The following is a description of a gene set: Genes predicted to be targets of miRBase v22 microRNA mmu_miR_6973a_3p in miRDB v6.0 with MirTarget v4 prediction scores > 80 (high confidence targets). Mouse Gene Set: MIR_6973A_3P species: Mus musculus from publication Chen Y, Wang X (PMID 31504780), and this is the list of marker genes: Lonrf1, Efr3a, Asgr1, Plek, Msx3 (NCBI Gene Id 212466), Mgl2, Ankrd28, Dgke, Slc38a6, Tusc1, Zfp652, Lsm5, Pex13, Kdm2a, Lipo2, Dcc, Mdc1, Dstn, Ccdc73, Scn2a, Kpna4, Cask, Phf6, Slc35f5, Hes7, Wasf1, Eif4a2, Cd28, Usp38, Tmprss11d, Clpb, Yipf5, Wdr76, Hc, Uty, Bola3, Pmaip1, Arhgap39, Ereg, Bmpr1a, Psd3, Dync1li2, Apob, Slc16a2, Dennd5a, Plekha8, Clta, Pcmtd2, Edil3 (EGF-like repeats and discoidin I-like domains 3), Tmc7 (transmembrane channel-like gene family 7), Cdk13, Chrnb1, Gpm6a, Cdh8, Csn1s1, Mbnl1, Cyp4a14 (NCBI Gene Id 269575), Fgd4